The following is a description of a gene set: studied in species Mus musculus Mouse Gene Set: CUI_LANGERHANS_IL4_RESPONSE_UP Cytokines mediate cell-cell communication in the immune system and represent important therapeutic targets. A myriad of studies have highlighted their central role in immune function, yet we lack a global view of the cellular responses of each immune cell type to each cytokine. To address this gap, the authors created the Immune Dictionary, a compendium of single-cell transcriptomic profiles of more than 17 immune cell types in response to each of 86 cytokines (>1,400 cytokine-cell type combinations) in mouse lymph nodes in vivo. A cytokine-centric view of the dictionary revealed that most cytokines induce highly cell-type-specific responses. For example, the inflammatory cytokine interleukin-1β induces distinct gene programmes in almost every cell type. A cell-type-centric view of the dictionary identified more than 66 cytokine-driven cellular polarization states across immune cell types, including previously uncharacterized states such as an interleukin-18-induced polyfunctional natural killer cell state. from publication Cui A, Huang T, Li S, Ma A, Pérez JL, Sander C, Keskin DB, Wu CJ, Fraenkel E, Hacohen N (PMID 38057668) Genes positively differentially expressed in cell type: Langerhans upon treatment with cytokine: IL-4 in mouse lymph nodes in vivo., and this is the list of marker genes: Scn3a, Tcaf2, Gsn, Cst3, Sft2d2, Idh1, Pik3cb, Ccl17, Mylk